Given this list of marker genes IFNGR1, RPS6KL1, PRSS8, MBTPS2, PTPMT1, SLC5A1, DDC-AS1, USP45, PHC3, SCARNA15, RAB29, ADGRE5, LINC00943, KCNH4, WFDC21P, LIPJ, CELSR1, CA14, IL10RB-DT, TUBB2A (NCBI Gene Id 92919), GTF3C3, ONECUT1, ADAP2 (ArfGAP with dual PH domains 2), TMEM184C, HSPA1L, HOXA11, ODAD2, PSMG1, CAPN13, TMEM273, RASL10A, LINC02145, NPAT, REXO1L1P, PLEKHG5, ZC3H12C, MARK4, PLXDC2, FTHL17, TOLLIP-DT, ZBTB24, AGO1, KMT5A, RAB38, MAPDA, STX1B (NCBI Gene Id 6805), EFCAB11, CHPF, TEX101, SLC25A3P1, NCAPD2, SKIL, TPCN1 (two pore segment channel 1), FAM177A1, FAM228B, SUGT1P1, ITGAE, RBP4, KIF28P, TMTC3, CXorf65, ZNF607, OXR1, AJAP1 (NCBI Gene Id 55966), GLT8D1, TLR1, SAT1, GCN1, PRXL2C, EMX2OS, RAB33A, ACTN3, SLC24A3 (NCBI Gene Id 96617), PRSS12, GUCY1B2, PAF1, PHYH (phytanoyl-CoA 2-hydroxylase), ABHD17B, CRTAC1, PLPPR5-AS1, MTFMT, CCDC181, GABRP, OBP2B, FAM117A, COL22A1, RIN3, BRCC3, GFOD3P, NFKBIZ, CXCR3, BLOC1S4, NDUFA8, SP4, C20orf144, PWRN2, H2BC14 (H2B clustered histone 14), ANKRD40, SLC25A5-AS1, QRICH2, AGMAT, ZNF524, RNF8, LRRC74B, ZNF214, EEF2K, ADD2, KISS1R, PIWIL2 (piwi like RNA-mediated gene silencing 2), TMEM87B, ITLN1, GRAMD1C, SPAST, EED, GOSR1, CDK5RAP1, SRA1, GYS2, MYCBPAP (NCBI Gene Id 84073), KISS1, TIMM23B, ACADSB, KAZN, TNFRSF13B, MCM6, OCA2, AXIN2, NHERF2 (NCBI Gene Id 9351), ANXA2P1, MIR622, NIPSNAP3A, ZBTB34, GRK6, CAST, UAP1L1, IFNLR1, C6, MFAP5, MMP2, AGGF1, GULP1 (GULP PTB domain containing engulfment adaptor 1), SRSF1, MARCHF2, IGF2BP3, GPR78, RYR3, CLDN8, MAP3K14-AS1, SLC2A3, MSTO1, CADM4, MDFI, NGEF, USP48, EDRF1, PAK2, TUBGCP5, LINC00309, SH3BP5-AS1, ORC3, TSPY1, GNE, DCPS, ZNF718 (zinc finger protein 718), TCFL5, BRD7P3, RILPL2, ENSG00000293136, TRNP1, KLHL6, GOLGA8IP (golgin A8 family member I, pseudogene), ZNF597, SMYD1, PDE6G, EMC4, IL10, NFE2L1, RRP36, MFSD4B, ADAMTSL4-AS2, RAB20, IRAK2, KLF9, COL4A1, GLYATL2, CFAP300, POC5, ANAPC11, FAM241B, LSR, PFKFB3, BMX, here is a description of the gene set: from publication Marigo I, Bosio E, Solito S, Mesa C, Fernandez A, Dolcetti L, Ugel S, Sonda N, Bicciato S, Falisi E, Calabrese F, Basso G, Zanovello P, Cozzi E, Mandruzzato S, Bronte V (PMID 20605485) Human Gene Set: GSE21927_SPLEEN_VS_TUMOR_MONOCYTE_BALBC_UP species: Homo sapiens Tumor growth is associated with a profound alteration of myelopoiesis, leading to recruitment of immunosuppressive cells known as myeloid-derived suppressor cells (MDSCs). Analyzing the cytokines affecting myelo-monocytic differentiation produced by various experimental tumors, we found that GM-CSF, G-CSF, and IL-6 allowed a rapid generation of MDSCs from precursors present in mouse and human bone marrow (BM). BM-MDSCs induced by GM-CSF+IL-6 possessed the highest tolerogenic activity, as revealed by the ability to impair the priming of IFN- -producing CD8+ T cells upon in vivo adoptive transfer. Moreover, adoptive transfer of syngeneic, GM-CSF+IL-6-conditioned MDSCs to diabetic mice transplanted with allogeneic pancreatic islets resulted in long term acceptance of the allograft and correction of the diabetic status. Cytokines inducing MDSCs acted on a common molecular pathway. Immunoregulatory activity of both tumor-induced and BM-derived MDSCs was entirely dependent on C/EBP transcription factor, a key component of the emergency myelopoiesis triggered by stress and inflammation. Adoptive transfer of tumor antigen-specific CD8+ T lymphocytes resulted in therapy of established tumors only in mice lacking C/EBP in myeloid compartment. These data unveil another link between inflammation and cancer and identify a novel molecular target to control tumor-induced immune suppression. We used gene expression analysis to identify those factors, secreted by tumor-infiltrating MDSC, which could drive emathopoiesis. Moreover we compare gene expression profile of tumor-induced MDSC, obtained from either the spleen and the tumor infiltrate of tumor bearing mice, and in vitro bone marrow-derived MDSC. Genes up-regulated in CD11b Spleen from BALBc mouse versus CD11b Tumor from BALBc mouse.